The following is a description of a gene set: Removal of aminoterminal propeptides from gamma-carboxylated proteins Human Gene Set: REACTOME_REMOVAL_OF_AMINOTERMINAL_PROPEPTIDES_FROM_GAMMA_CARBOXYLATED_PROTEINS studied in species Homo sapiens, and this is the list of marker genes: BGLAP, PROS1, F7, GAS6, F9, F10, PROC, F2, PROZ, FURIN